The following is a description of a gene set: The process in which a relatively unspecialized cell acquires specialized features of a neuron whose cell body resides in the peripheral nervous system. Human Gene Set: GOBP_PERIPHERAL_NERVOUS_SYSTEM_NEURON_DIFFERENTIATION studied in species Homo sapiens, and this is the list of marker genes: TBCE, NTRK2, HAND2, SLC25A46, ISL1, NEFH (NCBI Gene Id 4744), ISL2, RUNX1, HOXD10, HOXD9, RUNX3, POU4F1, ETV1, ASCL1, ONECUT2, VCAM1